The following is a description of a gene set: from publication Chen Y, Wang X (PMID 31504780) species: Homo sapiens Human Gene Set: MIR6832_3P Genes predicted to be targets of miRBase v22 microRNA hsa-miR-6832-3p in miRDB v6.0 with MirTarget v4 prediction scores > 80 (high confidence targets)., and this is the list of marker genes: HGF, ATG9A, EPHB2, ZFP91, RNF170, TAF2, NDRG3, COL6A6, RELL1, NRBF2, CPD, SP6, AMACR, CCDC103, IGF2R, PHF13, DPF1, LRRC40, ZC4H2, NDST3, PKIA, GPR88, RIMS1, ERLIN2, NFIB, GDNF, FOXC1, ANGPTL2, WDR26, CALHM4, YPEL4, ADCY6, SPRED1, CUX1, TMOD3, ADRA1A, ZXDC, WWC3, POU2F1, LRP2, NR3C1, KHDRBS3, RBMS3, ONECUT2, SNAI2, XBP1, ANGPT1, GET4, TFEC, FAN1, KLF12, ARHGEF33, AP2A2, CSRNP2, ANKRD17, EPHA7, BLZF1 (basic leucine zipper nuclear factor 1), RERE, EVA1C, MAP1LC3B2, RPS6KC1, KCNJ5-AS1, CORO1C, EXOSC9, ARHGEF37, SOCS6 (NCBI Gene Id 9306), HOOK3, EFNB3, WNK3 (NCBI Gene Id 65267), KDM2A, MAP4K5, ANKRD13C, ZFHX4, AEBP2, ELOVL6, PTPRR, ANKRD13A, ENTHD1, SH3TC2, DNAJB1, FAM114A1, GATA6, OXNAD1, SLC16A6 (solute carrier family 16 member 6), VAPB, BAZ2A, DMTF1, TP53INP1, ST7, GOLGA6B, SLC43A1, SNX6, TENT5A, FGFR1OP2, DCUN1D3 (defective in cullin neddylation 1 domain containing 3), DYRK1A, MAP3K3, EZR, MLXIP, AP1S2, SNRK, INPP4A (inositol polyphosphate-4-phosphatase type I A), SOX4, ESRRG, ATXN10, MBNL1, FNIP1, RPL7L1, GLIS3, RAP2C, SEC11C, ESYT2, PPP1R1C, TCF12, SYNJ2BP, SFXN1, KPNA1, ZDHHC17, ELAVL3, VTA1, MAPK9, TAF5, SLC38A7 (NCBI Gene Id 92914), PRR32, CAVIN2, DLG5, NOTCH2, PIGM, TMEM237, ZBTB34, TRRAP, TRIP12, MGAT3, ITPR1, HNRNPA1, RAB10, ANGPTL1, MAML1, SOWAHC, RSPO3, SLC37A3, EBF2, PTPRJ, USP47, EPHA5, YTHDF3, RABGAP1L, EPHA1, COPS6, RICTOR, RAB22A, OSGIN2, KLHL29, APH1A, CDH4, NAPG, USP46, ZNF506, SEL1L, FBXW7, AGPAT3, HAS2, HDAC9, SLC46A3 (NCBI Gene Id 283537), ZNF600, HCAR3, MTMR6, CDK6, PLCB1, RHOBTB3, GNB1, KXD1, NRARP, WEE1, TOX3, PPM1K, TNRC6B, ASXL3 (NCBI Gene Id 80816), HMGA2, NBEA, UBN2, TTYH1, FAM168B, PDCD6IP, TMEM156, MOXD1, JRKL, LPAR1, NR4A2 (nuclear receptor subfamily 4 group A member 2), ZCCHC24, EPHB6, MAPK1IP1L, PARVB (parvin beta), UBLCP1, BMPR1A, ANKRD44, RUNX2, GOLGA6A, JARID2, CREB5, MAP1LC3B, BCL9, FRAS1, FARP1, ZNRF2, GPM6A, HCAR2, NFATC3, CPNE8, DNAAF9, ABRAXAS2, FHIP1B, C1orf43, CLMP, HNRNPA2B1, PRRX1, CLIP4, PLXNA2, PPP3CC (NCBI Gene Id 5533), THSD4, ZBTB20, ZFP37, FJX1, NEXMIF, PRELID3B, TMTC2, GOLT1B, AFG1L, TRAM2, TOMM70, COX5A, SEC63, PHOX2B, DR1, NUAK1, KCTD1, FBN2, C9orf72, NOVA1, SAMD5, PPP1R9A, KHDRBS1, SOX11, CLPX, MCOLN1, B3GNT5, CRKL, LATS1, IGF2BP1, EDEM1, NIPBL, DRAP1